Given this list of marker genes St8sia2, St6gal2, Neu1, St3gal2 (NCBI Gene Id 20444), St6galnac4, Neu2, Cmas, Nanp, St3gal5, Neu4, St6galnac2, St6galnac3, Npl, Neu3, Nans, St3gal3, St3gal4, St6galnac1, St8sia4, St8sia3, St6galnac6, St8sia5, here is a description of the gene set: part of: Synthesis of substrates in N-glycan biosythesis electronically inferred by orthology from the curated human pathway Reactome Pathway: Sialic acid metabolism species: Mus musculus This event has been computationally inferred from an event that has been demonstrated in another species.<p>The inference is based on the homology mapping from PANTHER. Briefly, reactions for which all involved PhysicalEntities (in input, output and catalyst) have a mapped orthologue/paralogue (for complexes at least 75% of components must have a mapping) are inferred to the other species.